Given this list of marker genes Kif14, Ccdc146, Dnah9 (NCBI Gene Id 544786), Dlgap5, Sac3d1, Ckap2, Lca5, Enkur, Nlrp5, Ccnb1, Pard6b, Bcl2l10, Arl3, Ccdc57, Spmip9, Ccnf, Zpr1, Gm10662, Sun2, Gen1, Kxd1, Eml1, Parp3, Ly6k, Ulk4, Cep97, Xrn2, Cfap68, Ttll4, Septin1, BC034090, Cep350, Disc1, Tacr2, Kif19b, Spmip6, Tubb6, Tektl1, Wdr19, Fgf13, Tln1, Ppp2r1a, Spry1, Rab1a, Nphp4, Katnb1, Ift20, Fuz (fuzzy planar cell polarity protein), Pex14, Ska1, Ccdc38, Rp1, Clasp2, Tbce, Eml2, Misp, Catsper4, Brsk2, Mst1, Mos, Ninl, Caly, Ankrd53, Calml4, Tacc3 (NCBI Gene Id 97263), Katnal2 (NCBI Gene Id 76984), Cfap45, Ttll9, Tubg2, Dnah14, Poldip2, Katnip, Mkks, Pde4dip, Prss55, Cfap69 (cilia and flagella associated protein 69), Dnaaf11, Lca5l, Ino80, Ddb1, Sgo1, Plk4, Dynlt3, Tekt1, Mecp2, Ttll13, Memo1, Stk36, Ppp1r12a, Prkaa2, Foxj1 (NCBI Gene Id 15223), Dnaaf3, Pex13, Llgl1, Arl8a, Pierce2, Cep68, Kif18b, Kif1a, Tuba1c, Cfap73, Nme7, Eml3, Inppl1, Aqp4, Ift46, Rock1, Lrrc23, Arhgef1, Stmn2, Copg1, Vcp, Ssna1, Prkaa1, Wdr72, Armcx3, Cep126, Ankfn1, Rab17, Uxt, Pdcl2, Intu (inturned planar cell polarity protein), Haus4, Gk2, Gja1, Kash5, Spag6l, Tppp2, Calm4, Dicer1, Ift140, Borcs8 (BLOC-1 related complex subunit 8), Nup62, Stag2, Ccdc88a, Txndc9, Dnal4, Dydc1, Stmnd1, Golga2, Stmn4, Alms1, Dnai7, Cfap70, Saxo4, Wdr62 (NCBI Gene Id 76446), Mark4, Cep78, Spag6, Itgb1bp2, Cfap144, Ckap5, Dnaaf6rt, Pura, Klhl42, Gpsm1, Flot2, Chordc1, Cfap97d1, Rac1 (Rac family small GTPase 1), Hif1a, Cul7, Map2k1, Atg5, Slc22a14, Mcidas, Dctn1, Kif3c, Dcaf13, Catspere2, Map1b, Tacr1 (NCBI Gene Id 21336), Dynlt5, Nedd1, Nme5, Specc1l, Gapdh, Ttbk2, Iqcn, Dync2i1, Bnip2, Dync1h1, Chek2, Lmna, Rsph6a, Ccdc159, Atxn3, Katna1, Rab27b, Gtf2b, Itgb1, Klc2, Dusp3, Tubg1, Rnf4, Madd, Akap4, Kif1c, Ldhc, Iqub, Agbl4, Slk, Dnai3, Kif2c, Spata7, Terf2, Haus3, Deup1, Iqcf1, Catsperz, Cfap161, Cetn3, Rae1, Bloc1s2, Adam3, Dnaaf5, Borcs6, Ripor2, Camsap3 (NCBI Gene Id 69697), Mei1, Tacc1, Tmf1, Ccnl2, Rabl2, Rab11a (RAB11A, member RAS oncogene family), Rab21, Cluap1, Cdc14b, Tcte1, Wfdc6a, Odad1, Sbds, Chmp1b2, Arhgef10, Dnali1, Rhoa, Stag1, Hepacam2, Ttll7, Rgs14, Dvl1, Ccdc88b, Cfap44, Spag5, Gm4513 (NCBI Gene Id 101055864), Efhb, Kiz, Azin1, Mapre3, Atf5, Cfap206, Tac4, Rnase9, Ap3s2, Dpcd, Spry2, Wdr73 (NCBI Gene Id 97396), Stil, Ccdc170, Haus2, Cfap47, Nsfl1c, Ubxn2b, Cfap43, Efcab6 (EF-hand calcium binding domain 6), Tekt3, Ccnyl1, Flna, Trim54, Stmn3, Wasf1, Dynll1, Lsm14a, Hspb1, Map7d3, Nudc, Ccdc8, C2cd6, Prm3 (NCBI Gene Id 407832), Bicdl1, Catsperd, Htr1a, Jhy, Npm1, Fbxw11, Rgn, Gm10668, Trim36, Tub, Tubb3, Numa1, Smc3, Kif27 (NCBI Gene Id 75050), Bicd1, Spem1, Myo5a, Pkhd1, Tpr, Ccsap, Cc2d1a, Cc2d2a, Spmip5, Axin1, Slc39a12, Fam107a, Haus6, Mreg, Stau2, Kif13b, Phldb2, Ttll2, Knstrn, Senp6, Setd2 (NCBI Gene Id 70927), Uchl1, Cyld, Tubal3, Map9, Tuba3a, Snapin, Ccdc69, Map7d2, Csnk1d, Ppp2r1b, Ift122, Tbcb, Pard6g, Tubb4b, Kifc2, Wdr47, Ccdc39, Cwh43, Epha3, Cdc42, Sgk1, Cul9, Dynlt2a1, Kpnb1, Kif2a, Cep128, Kif20a (NCBI Gene Id 19348), Map3k11, Kif26b, Rfx3, Dnaaf4, Trpv4, Gas8, Ttc21b, Lrrc61, Kat5 (NCBI Gene Id 81601), Tubgcp3, Wdpcp, Zmynd12, Prune1, Cenpe, Usp33, Dynlrb1 (NCBI Gene Id 99273), Kif11, Celsr2, Nuf2, Cntn2, Cep85, Calm5, Cfap298, Dnaaf10, Pgk2, Clip2, Spc25 (SPC25, NDC80 kinetochore complex component, homolog (S. cerevisiae)), Ppp1r35, Dnai2, Mak, Bbs1, Mcph1, Gm5890, Ska2, Macf1 (NCBI Gene Id 97195), Garin5b, Catspere1, Neto1, Chmp1b, Kat2b, Rbm14, Ccser2, Ccdc66, Mark2, Slirp, Spmip8, Ttll3, Borcs5, Cenpj, Cfap95, Dynlt1b, Irgc, Trak2, Ttll6, Haus8, Afg2b, Dnah11, Tubb4a, Apob, Spdl1, Diaph1, Dctn3, Ccdc187, Pla2g3, Ptk2, Cdc20b, Tbcel, Ift56, Tpgs1, Abl1, Ccdc78, Gm6882, Ift22, Hspa1a, Kif13a, Cdk5rap2, Cep295, Dzip1, Tuba1b, Dnah2, Smn1 (NCBI Gene Id 20595), Tnp1, Ccdc65, Tubgcp6, Pldi, Pacrg, Arhgap21, Map7d1, Aurkc, BC048507, Cdk2ap2, Syne2, Slc9c1, Spmip10, Chmp1a, Ttll8, Ift70a2, Kif28, Wee1, Ranbp10, Ppp2r3c (protein phosphatase 2, regulatory subunit B'', gamma), Zfp207, Pibf1, Drg1, Bora, Spire2, Katnbl1, Dnah3, Cetn4, D7Ertd443e, Cfap91, Cav3, Xrcc2, Met (NCBI Gene Id 194383), Bloc1s3, Rsph1, Ctnnb1, Haus7, Ttc21a, Ropn1, Cep290 (centrosomal protein 290), Srgap2, Fsip1, Cenpa, Pafah1b1, Tac2, Efna5, Dync2h1, Tubb1, Dnah17, Kif9, Togaram1, Sass6, Stau1, Xpo1, Khdc3, Anxa5, Myh9, Cryaa, Rttn, Spef2, Cep135, Spag16, Gnai1, Cfap57, Sirt1, Kif5b, Cep44, Cfap65, Haus1, Ccdc42, Ift70b, Bccip, Kifc5b (NCBI Gene Id 94117), Cdc14a, AU040320, Rock2, Bloc1s4, Hdac3, Ropn1l, Ccdc40, Sybu, Bloc1s5, Ttll5, Bicd2, Vbp1, Clip3, Nckap5l, Pkd1, Dnm2, Garin5a, Pcnt, Clxn, Gm5157, H1f6, Cep250, Hdgfl3, Ift80, Bbs4, Sik3, Trdn, Hspa1b, Catsper1, Rpgr, Cript, Dclk2, E2f4, Dync2li1, Brca2, Dync2i2, Garin3, Mapt, Ccdc120 (coiled-coil domain containing 120), Aaas, Ift57, Copg2, Nubp1, Map1a, Sun1, Ranbp1, Cdk5r1, Cfap90, Map10, Fyco1, Slc22a16, Tubgcp4, Ofd1, Stard9, Cabs1, Prdm14, Ccdc63, Cabcoco1, Slc9b1, Pten, Ints13, Gas2l2 (growth arrest-specific 2 like 2), Wdr35, Cimip2a, Akap3, Ttl, Gsk3b, Fsd1, Ube2b, Ddx4, Atxn7, Kif5a, Ccn2, Spg7, Cdh5, Spaca9, Rp1l1, Nek10, Slc9b2, Wnt3a, Dnah5, Aunip, Tuba1a, Chmp6, Bicdl2, Tekt2, Hook2, Pard6a, Cfap126, Poc1a, Trak1, Rcc1, Tssk4, Bbs12, Ash1l, Pierce1, Tektip1, Actr10, Brsk1, Cnih2, Gsk3a, Chek1 (NCBI Gene Id 97555, checkpoint kinase 1), Chmp2a, Map6d1, Pltp, Ppfibp1, Atg16l1, Pard3b (NCBI Gene Id 72823), Zbed3, Sod1 (NCBI Gene Id 319325), Ccdc68, Lrrc46, Cntln, Tle6, Dynll2, Tnp2, Prkcz, Celf3, Agtpbp1, Poc1b, Cep43, Iqcg, Kif15, Tuba4a, Cdk2, Kif3b, Neurl1a, Chmp4c, Cep63, Cntrob, Odad2, Septin4, Armc3, Slc16a1, Kif1b, Ap3b2, Cdc42bpa, Abraxas2, Wdr90 (WD repeat domain 90), Dnah10, Fbxo5, Gpsm2, Tmem201, Apc2, Hoatz, Map4, Cav1, Dlg2 (discs large MAGUK scaffold protein 2), Ing2, Chmp7, Nefm, Atat1 (NCBI Gene Id 73242), Dynlt4, Ntmt1, Ttc12, Ap3d1, Ttll11, Odad4, Dync1li1, Rasgrp1, Akap9, Xrcc3, Sord, Inpp5b, Map7, Gapdhs, Sdccag8, Hook1, Cltc, Apc, Trim37, Rhox5, Gba2, Son, Qrich2, Dnajb13, Togaram2, Capn6, Dnah8, Arl8b, Cep76, Limk2, Dctn6, Ccdc61, Uhrf1, Cln3, Hsbp1, Tekt4, Lztfl1, Llgl2, Tacr3, Ssx2ip, Ccnb2, Nefl, Misfa, Kif18a (NCBI Gene Id 99225), Dnhd1, Dyrk1a, C2cd3, Gcc2, Pclaf, Tex101, Prickle1, Nde1, Vps4b, Wrap73, Pex1, Cep72 (centrosomal protein 72), Cep19, Tuba8, Ift43, Traf3ip1, Plk5, Dnah7c, Dnaja1, Dag1, Cep192, Cfl1, Tssk6, Plk2, Gm6176, Ift172, Tmem108, Poc5 (NCBI Gene Id 67463, POC5 centriolar protein), Tbc1d32, Hsph1, Daw1, Kif21a, Aspm, Cep152, Erbb2, Spice1, Ak7, Rps3, Fkbp4, Cfap119, Aurkb, Mgarp, Armc12, Cdkn1b, Kat2a, Efcab11, Ilk, Diaph3, Adcy3, Washc1, Mapk8ip3, Mns1, Cgn, Ncor1, Fez1, Insl6, Ccdc88c, Map1s, Rhot1, Rangrf, Tbc1d21, Dnah12, Smcp, Wfdc6b, Mapk15, Dnah7b, Pak1, Map2, Kifc1 (kinesin family member C1), Stard7, Nat10, Dcx, Mybl2, Cfap58, Fsip2, Spire1, Clasp1, Cfap61, Kif19a, Fam110a, Arhgef7, Chmp4b, Lyst, Stmn1, Cryab, Dnal1, Ktn1, Rho, Kif5c, Bbs2, Garin2, Gmnc, Dlg1, Spast, Spata33 (spermatogenesis associated 33), Fignl2, Cenatac, Nusap1, Fbxo24 (NCBI Gene Id 71176), Mtcl1, Bbof1, Megf8, Taf7l, Catsper2, Ift70a1, Klc4, Ift81, Dnaaf2, Nherf1, Odad3, Crocc, Kif20b, Cfap210, Nav1, Adam7, Birc5, Clip4, Taok1, Rsph4a (radial spoke head 4 homolog A (Chlamydomonas)), Rsph14, Mid1, Ift52, Tubgcp5, Ooep, Kif21b, Fes, Dusp21, Sfpq, Prc1, Dynlt2b, Dnah6, Cfap276, Or4m1, Ap3m1, Obsl1, Chmp3, Phldb1, Psrc1, Brca1, Hnrnpu, Dixdc1, Mapk8, Fbxw5, Pcm1, Mzt1, Ss18, Dync1i1, Kif4, Pard3, 4933427D14Rik, Kif26a, Htt, Tppp3, Dctn2, Kif6, Cdk11b, Fgf10, Ttll1, Cacna1e, Spag1, Map6, Adcy10, Ccnb1-ps, Dock7, Dnah1, Tpx2, Cep20, Bcas2 (NCBI Gene Id 99556), Cimip2c, Rabgef1, Bloc1s1, Ribc2, Hspa8, Trim58, Cfap141, Cep120, Borcs7, Trim46 (tripartite motif-containing 46), Wt1, Hdac6, Tppp, Efhc1, Ccdc103, Tekt5, Hook3, Chmp2b, Pdcd6ip, Cimap1a, Lamp1, Mark3, Ap3m2, Cfap54, Sugt1, Tubd1, Mapre2, Rsph9, Dnai4, Ubb, Ezr, Kif22, Mid1ip1, Catsper3, Camsap2, Pfn4, Washc5, Ift74, Cfap53, Bmerb1 (NCBI Gene Id 67254), Dnaaf1, Dync1li2, Incenp, Bsn (bassoon, NCBI Gene Id 12217), Spinkl, Nek2, Dnah7a, Cyb5d1, Eno4, App, Git1, Actr3, Agrn, Plk3, Slain1, Spag8, Cfap251, Haus5, Tubb5, Ccr6, Kif7, Gas2l1, Ccnl1, Dynlrb2 (dynein light chain roadblock-type 2), Kif16b, Spef1 (NCBI Gene Id 70997), Chmp5, Kifc3, Klc3, Tmem67, Dync1i2, Ank3, Chd3, Kif23, Cep70, Gabarap, Drc7 (dynein regulatory complex subunit 7), Kifap3, Gapdhrt, Spg11, Aurka, Defb1, Eppin, Lrguk (leucine-rich repeats and guanylate kinase domain containing), Sapcd2, Dnaaf6, Nckap5, Plk1, Atp1a4, Ndc80, Kif12, Fer, Spag17, Kif24, Gas2l3, Mapre1, Cep131, Enkd1, Vangl1, Snca, Camsap1, Mad2l1, Invs, Tmem230, Hydin, Kifbp (kinesin family binding protein), Cplane2, Ift27, Pax6, Tbcd, Dtnbp1, Tubgcp2 (NCBI Gene Id 74237), Cetn2, Arhgef2, Ptpa, Uvrag, Rhot2, Kif3a, Mdm1, Defb37, Bloc1s6, Cfap74, Cilk1 (ciliogenesis associated kinase 1), Ift88, Cetn1, Rsph3b, Nsun7, Efcab9, Zmynd10, Nme8, Tmem232, Inpp5j, Rnase10, Cenph, Tubb2b, Gadd45a, Ap3s1, Tac1, Drc1, Abraxas1, Slain2, Tubb2a, Atrx, Clip1, Cdk1, Kif17, Eml4, Cfap157, Tube1, Vps13a, Cfap20, Cdca8, Ccdc15, Snhg15, Spem3, Chp1, Cfap52 (cilia and flagella associated protein 52), Hap1, Yif1b, Cimip2b (NCBI Gene Id 329831), Ccdc13, Cfap221, Lzts2, Cep295nl, Racgap1, Meig1, Espl1, Smc1a (structural maintenance of chromosomes 1A), Atp2b4, Cdc20, Tacc2, Ccp110, Dnai1, Arl2, Nefh, Cib1, Stk11, Txndc2, Nav3, Klc1, Ift25, Gda, Fmn2, Katnal1, Ska3, Ndel1, Vdac3, Kif2b, Ribc1, Zw10, Cfap107, Gapdhrt2, Ap3b1, Actr2, Armc2, Chrna7, Ttc29, Mlh1, Dst, Nin, Efhc2, Cfap100, here is a description of the gene set: species: Mus musculus Mouse Gene Set: GOBP_MICROTUBULE_BASED_PROCESS Any cellular process that depends upon or alters the microtubule cytoskeleton, that part of the cytoskeleton comprising microtubules and their associated proteins.